Given this list of marker genes DIAPH3, FOXL1, PRORP, MPDU1, OTOF, here is a description of the gene set: species: Homo sapiens Human Gene Set: HP_ABNORMALITY_OF_THE_ACOUSTIC_REFLEX An abnormality in the reflexive contraction of the middle-ear muscles in response to sound stimulation. Abnormality of the acoustic reflex